Given this list of marker genes Gsk3b, Mapre2, 4933427D14Rik, Ppp1r9b, Abhd17a, Cript, Cep63, Bicd1, Hook3, Fam83d, Disc1, Stk3, Gas2l1, Spag5, Dctn2, Htr2a, Kif20b, Ttk, Pibf1, Mark4, C2cd3, Nsfl1c, Nup62 (nucleoporin 62), Gas2l2, Abl1, Mapre1, Cttnbp2nl, Fam83h, Abhd17c, Luzp1, Ttbk2, Nudcd3, Apc, Rab11fip3, Ccdc14, Dvl1, Stil (Scl/Tal1 interrupting locus), Cep78, Numa1, Cep250, Cep192, Csnk1d, Filip1, Pcm1, Rab11a, Cep131, Diaph1, Mid1, Hnrnpu, Aurka, Filip1l, Ubxn2b, Snx10, Mcph1, Htt, Klhl21, Champ1, Cep350, Abhd17b, Pard6a, Bbs4, Mapre3, Mid2, Trim69, Map1a, Cep72, Cep83, here is a description of the gene set: Mouse Gene Set: GOBP_PROTEIN_LOCALIZATION_TO_CYTOSKELETON A process in which a protein is transported to, or maintained in, a location within the cytoskeleton. species: Mus musculus